Given this list of marker genes PAFAH1B1, MBOAT7, CDK5R1, LRP8, RELN, COL3A1, CDK5, DAB2IP, GLI3, BMERB1, NR2E1, CTNNB1, CDK5R2, SOCS7 (suppressor of cytokine signaling 7), DAB1, ADGRG1, here is a description of the gene set: The detachment of cells from radial glial fibers at the appropriate time when they cease to migrate and form distinct layer in the cerebral cortex. Human Gene Set: GOBP_LAYER_FORMATION_IN_CEREBRAL_CORTEX species: Homo sapiens